The following is a description of a gene set: studied in species Mus musculus The spontaneous peristaltic movements of the stomach that aid in digestion, moving food through the stomach and out through the pyloric sphincter into the duodenum. Mouse Gene Set: GOBP_GASTRIC_MOTILITY, and this is the list of marker genes: Gpr39, Ghsr, Ghrl, Nmu, Crhr2, Nppc, Tymp, Npr2